The following is a description of a gene set: from publication Lake BB, Chen S, Hoshi M, Plongthongkum N, Salamon D, Knoten A, Vijayan A, Venkatesh R, Kim EH, Gao D, Gaut J, Zhang K, Jain S (PMID 31249312) species: Homo sapiens Human Gene Set: LAKE_ADULT_KIDNEY_C24_ENDOTHELIAL_CELLS_AEA_AND_DVR, and this is the list of marker genes: ENPP2, CALD1, NAMPT, MTUS1, HSP90AB1 (NCBI Gene Id 3326), PLCB1, KCTD12, IL6ST, ID1 (NCBI Gene Id 96820), RPL4, YWHAB, NFKBIA, EBF1, DNAJA1, EPAS1, RPL5, DPYD (NCBI Gene Id 1806), TMTC1, RASAL2, MACF1, PIK3C2A, IQGAP1, APBB2, KIF5B, RPS5 (NCBI Gene Id 6193), PSAP, PTPRM, SYNE1 (spectrin repeat containing nuclear envelope protein 1), ADAMTS6, SOX5, LIMCH1, TPM3, ABI3BP, CD46, ELMO1, APP, RPS2, TJP1 (NCBI Gene Id 7082), HSPH1, IFITM2, DOCK4, RPL10, HSP90B1, RPL14, B2M, CDC42BPA, SPARC, FBXL7, FTL, FCHSD2, SRGN, VIM, PLPP1, EMP1, ADAMTS9, HLA-DRA, PTPRB, ACTG1, SYN3, KLF12, TTC28, CRYBG3, TPT1, DUSP1, ADGRF5, TMSB4X, CLIC4, TMSB10, EMCN, RPL11, ARGLU1 (arginine and glutamate rich 1), RPL15, PTTG1IP, PABPC1, PECAM1, RHOA, AQP1, RPL3, AKAP13, ADAMTS1, PDE3A, IFITM3, THSD7A, PLCB4, ADGRL4, PODXL, CRIM1, UTRN, CLDN5, HLA-DRB1, RPS6, RBMS3, DEPP1, SP100, LDB2, TACC1, ST6GALNAC3, EXOC6, ZEB1, MEF2A, CD93, WWTR1, EGFL7, PDLIM5, ARHGAP26, UBE2D3, TIMP3, UACA, RPLP0, DST, HLA-E, MYL6, RPS16, TM4SF1, PTMA, STOM, HSPA5, CD59, RALGAPA2, NPM1, A2M, THSD4, RPLP1, HLA-B, MYL12A, RPS18, MEIS2, AHNAK, ARL15 (ADP ribosylation factor like GTPase 15), FLT1, MBNL1, PTPRG, RPL19, CHRM3, AKT3, BMPR2, MEF2C, H3-3B, CALM1, PALMD, EXOC6B, DOCK9, MYH9, EIF1, FOS, ROCK2 (Rho associated coiled-coil containing protein kinase 2), CD74, SRP14, HSP90AA1, TCF4, SPTBN1, MYL12B